Given this list of marker genes QDPR, DHFR, PYCR1, MTHFD1, NOXRED1, DHFRP1, MTHFD1L, BLVRB, AASS, DHFR2, PYCR3, PYCR2, MTHFD2, MTHFR, ALDH1L1, MTHFD2L, CRYM, ALDH1L2, here is a description of the gene set: Human Gene Set: GOMF_OXIDOREDUCTASE_ACTIVITY_ACTING_ON_THE_CH_NH_GROUP_OF_DONORS_NAD_OR_NADP_AS_ACCEPTOR Catalysis of an oxidation-reduction (redox) reaction in which a CH-NH group acts as a hydrogen or electron donor and reduces NAD or NADP. studied in species Homo sapiens